Given this list of marker genes ORMDL1, SPHK1, ORMDL3, PRKAA1, ABCA2, ORMDL2, here is a description of the gene set: species: Homo sapiens Human Gene Set: GOBP_NEGATIVE_REGULATION_OF_SPHINGOLIPID_BIOSYNTHETIC_PROCESS Any process that decreases the rate, frequency or extent of sphingolipid biosynthesis. Sphingolipid biosynthesis is the chemical reactions and pathways resulting in the formation of sphingolipids, any of a class of lipids containing the long-chain amine diol sphingosine or a closely related base (a sphingoid).